The following is a description of a gene set: Genes up-regulated in comparison of untreated macrophages at 4 h versus those treated with LPS (TLR4 agonist) at 4 h. studied in species Homo sapiens from publication Koziczak-Holbro M, Glück A, Tschopp C, Mathison JC, Gram H (PMID 18266302) IRAK-4 is an essential component of the signal transduction complex downstream of the IL-1- and Toll-like receptors. Though regarded as the first kinase in the signaling cascade, the role of IRAK-4 kinase activity versus its scaffold function is still controversial. In order to investigate the role of IRAK-4 kinase function in vivo, ‘knock-in’ mice were generated by replacing the wild type IRAK-4 gene with a mutant gene encoding kinase deficient IRAK-4 protein (IRAK-4 KD). Analysis of bone marrow macrophages obtained from WT and IRAK-4 KD mice with a number of experimental techniques demonstrated that the IRAK-4 KD cells greatly lack responsiveness to stimulation with the Toll-like receptor 4 (TLR4) agonist LPS. One of the techniques used, microarray analysis, identified IRAK-4 kinase-dependent LPS response genes and revealed that the induction of LPS-responsive mRNAs was largely ablated in IRAK-4 KD cells. In summary, our results suggest that IRAK-4 kinase activity plays a critical role in TLR4-mediated induction of inflammatory responses. Human Gene Set: GSE9037_CTRL_VS_LPS_4H_STIM_BMDM_UP, and this is the list of marker genes: PROS1, CNOT6L, DOK1 (docking protein 1), SNX2, NLRX1, MYOZ2, WDR11, LYL1, AK3 (adenylate kinase 3), PRRC1, MINDY1, ACSL3, SLC6A6, RBM47, SLC25A26, ERLEC1, ANAPC4, TPRKB, KBTBD3, PPCDC, RAB14, RPA1, CDIN1, ALG2, ANKRD50 (ankyrin repeat domain containing 50), SLC25A20, CYB561A3, FUBP3, TPP1, MARVELD1, PYCR2, IVD, MGAT5, HES3, DTNBP1, RANBP6, HAS2, CCDC92, SUMF1, PRICKLE1, TEDC2, SMARCB1, DYNLT2B, RPLP2, HLA-DMB, ATF7IP, ILVBL, TEF, TMEM120A, TMLHE, HABP4, NOSTRIN, DLG3, ECSIT, VAV3, IKBIP, ABCD1, YWHAH, AP4E1, IPO5, AP1B1, CCDC47, UBR1, RMND1, DHRS1, FBXO16, SLC29A3, POC1B, CRYBG1, MFSD6, PALM, MAP3K12, SFRP2, KDSR, IGFBP4 (insulin like growth factor binding protein 4), GZF1, GPR180, CASQ1, SIGMAR1, MYO5A, FRMD4A, CCDC6, RUFY1, FGF4, KAT2B, KLF9, RNF128, KLF17, MAPK12, ACLY (NCBI Gene Id 47), DHX57, FBXO8, BTBD1, ENTPD5, PIGF, NUP93, FMNL3, SKP1, INTS10, SOBP, NEURL2, CNP, PVALB, DARS1, NUDT12, SOCS6, GLUD1, ATP5F1C, DAB2, IGF2R, FABP5, RILPL1, MRPL11, MBD2, UTP6, CTNS, SLC5A11, TACC1, HADHB, NDST1, SERINC3, TMEM87B, SAPCD1, CTSS, SLC25A35, PLPPR3, CMTM7, MDH1 (NCBI Gene Id 4190), ATXN1L, H2AC25, HDAC5, PARK7, LOXL3, FAM216A, ZNF471, TARS3, ANKH, CACNB2, MICAL1, CEP19, LAMTOR2, FKBP1B, MMP24, CAPN2 (calpain 2), MTMR9 (myotubularin related protein 9), TPD52, BBS12, C15orf39, MED7, FEN1, UBQLN2, ZNF235, SCRN3, DCTN5, DSCAML1, PBXIP1, RP2, MEGF9, OSBPL9, FZD7, PARP4, BTC, ATRX, AKAP7, PTCHD1, PPP1CC, BAG3, ANKMY2, PDK1, RFC2, MYMK, ARK2C, TNFRSF1A (TNF receptor superfamily member 1A), NT5C, MAPK14, RITA1, WNT5A, SCP2, FBXL17, STK17B, ARHGAP30, COMT, NONO, PDLIM2, SOX9, MTHFD1, LAPTM5, LBX1, CD5L, PLD4, TWF1, GTF3C4, ARHGAP9, TASL, H2AJ, SPPL2B, RAPGEF5, AATK, GNG10, MSRA (methionine sulfoxide reductase A)